The following is a description of a gene set: Human Gene Set: GOCC_MICROFIBRIL Extracellular matrix components occurring independently or along with elastin. Thought to have force-bearing functions in tendon. In addition to fibrillins, microfibrils may contain other associated proteins. species: Homo sapiens, and this is the list of marker genes: EFEMP2, FBN3, LTBP4, ADAMTSL5 (ADAMTS like 5), FBN2, THSD4, ADAMTS10, MFAP4, FBN1, MFAP5, MFAP1, LTBP1, MFAP2